Given this list of marker genes HSP90AA5P, KIFC2, HSP90AB1, ASCC3, ATP2B2, KIF22, KIF1A, ACTB, BCS1L, DNAH3, ABCA1, ATP5F1B, TAP1, DDX50, HSP90AA2P, DDX60, KATNA1, ATP9B, KIF2A (kinesin family member 2A), CHD3, HSP90B2P, KIF20A, SMC1B, CCT5, RAD51 (RAD51 recombinase), KIF5C (kinesin family member 5C), MTREX (NCBI Gene Id 23517), RIGI, FIGNL1, ATP10A, VPS4A, NLRP1, PMS2P1, KIFC1, ATP10D, CLPX, HSPA1B, BRIP1, TCP1 (NCBI Gene Id 6950), ABCF3, SNRNP200, ATP11C, ABCC3, DDX24, DDX59, PMS2, AFG1L, PSMC6, SHOC1, ATP6V1G2, ATP2A3, KIF6, MCM3 (NCBI Gene Id 4172), ATAD1, SWSAP1, INO80, ATP8B2 (NCBI Gene Id 57198), DNAH7, NLRP3, MSH2, DMC1, DDX47, RUVBL1, RFC5, KIF19 (NCBI Gene Id 203397), ACIN1, CCT6B, POLQ, ABCC8, BLM, DDX20, RUVBL2, FBH1, HELQ, TWNK, HSPA7 (heat shock protein family A (Hsp70) member 7 (pseudogene)), ALPL, RAD50, CDC6, ATP6V1G3, EIF4A2, KIF5B, GPN1, MCM6, VWA8, KIF1B, CHD9, SRP54 (signal recognition particle 54), DDX1, DHX40, DHX38, TRAP1, C10orf88, FIGN, DHX9, CFTR, ABCB7, KIF3C, CLPB, DDX23, SMC4, ABCF1, CCT6A, PIF1, DNAH9, TOR4A, ORC4, CHTF18, ERCC3, DNAH6, ABCC1, HSPA8, SMC3, ATP2C1, EIF4A3, KIF20B, ABCG2, ABCA4, GET3, DDX55, CHD1, ERCC2, ABCD1, XRCC6, MDN1 (NCBI Gene Id 23195), YTHDC2, NAV1, HSP90AB4P, KIF12, NAIP, KIF16B, SUPV3L1, VCP, ATP13A5, TDRD9, ATAD5, RFC2, ABCC5, KIF5A, SPG7, LONP1, ATAD3B, CHD2, ATP9A, CARNS1, RAD54L2, ABCC11, ATP10B, FANCM, ATP13A3, MCM8, KIF28P, HELB, SMC1A, MYO19, ABCB10, ABCG5, ATP13A2, ATP13A4 (ATPase 13A4), ERCC6L, KIF27, HSPA2, MYO3A, NAV3, NAV2, DHX34, KIF13B, KIF26A, ABCB6, ABCA6, HFM1 (NCBI Gene Id 374992), ATF7IP, DDX18, DDX60L (DExD/H-box 60 like), SMC5, NSF, ATAD3C, SMPDL3A, CCT8, HSP90AB2P, DDX42, UPF1, DHX8, KIF18B, KIF25 (NCBI Gene Id 3834), SRPRA, DDX19B, SMCHD1, PMS2P5, ABCG4, DDX25, CCT2, DHX16, NLRP10, KATNAL1, IQCA1, SLFN11, TDRD12, OLA1, ABCA9, MOV10, SMARCA5, KIF17, ABCA8, DHX35, ATP2B4, ABCA12, HSPD1, ATP6V1G1, PSMC4, ABCB11, DDX6, PMS2P6 (NCBI Gene Id 729453), DHX58, DHX15, ABCC9, SMC2 (structural maintenance of chromosomes 2), SMARCAD1, MCM7, ENTPD1, CCT7, RNF213, HSPA1L, BTAF1, MCM5, MYH8, DDX51, RSF1, NTPCR, ABCD2, ATP1A4 (NCBI Gene Id 480), ABCC6, XRCC5, MYO18A, TOR1B, CHD8, KIF3B, AQR, ABCB5, RAD54L, RFC1, TOR3A, ABCG1, DHX30, ABCA13, AFG3L2, PFN2, DDX28, ATP4A, HSP90AA4P, DDX5, ATP5F1A, HSP90B1, KIF21A, IQCA1L, DDX3X, CHD6, MCM2, MYH4, CCT4, RAD51D, SKIC2, WRNIP1, ATP5F1C, VPS4B, HSP90AB3P, KIF7, SMC6, KIF18A, DHX33, DDX41, PEX1, KIF15, PSMC2, DNAH10, ERCC6, KIF9 (kinesin family member 9), ATP1A3 (NCBI Gene Id 95633), MYO5A, IDE, RECQL, ABCE1, KIF13A, RFC4, ABCA5 (ATP binding cassette subfamily A member 5), TOR1A, ABCC4, DDX3Y, COQ8B, CHD4, ABCD4, MCM4, ATAD2, RTEL1, ABCB8, NUBP1, KIF3A, CHD1L, ATP12A, RHOBTB3, ABCC12, DDX27, MLH1, RECQL4, ATP8A1, KATNAL2, HSPA1A, ATP2C2, PEX6, DDX19A, HSPA14 (heat shock protein family A (Hsp70) member 14), KIF2B, DQX1, ABCA3, DDX39A, PMS1, ATP13A1, FIGNL2, ATP6V1A, ORC1, ABCC2, DDX11, ABCB4, DHX32, DDX17, ATAD3A, CCT3, CHD7, ATP2B1, ATP11A (NCBI Gene Id 84170), ABCA7, DDX10, DYNC1H1, ATP8B3, SPAST, DNAH2, ATP8A2, ATP2A2, ATP1A2, DDX49, MCM9, DNAH11 (dynein axonemal heavy chain 11), PSMC5, LONP2, SRCAP (NCBI Gene Id 10847), TRIP13, AK9, DDX31, HSPA6, MORC3, ABCA10, DDX46, MORC4, ATP8B4 (ATPase phospholipid transporting 8B4 (putative)), DDX54, MORC2, NVL, KIF23, DDX4, AFG2B, ABCB9, ATP11B, DHX36, ATP7A, ABCG8, DHX37, ABCA2, KIF14, CLU, HSPA13, IGHMBP2, DDX56, EIF4A1, G3BP1, DDX53, ATP8B1, DHX57, PSMC1, IFIH1, ATP2B3, YME1L1, AFG2A, KIF2C, KIF1C, ATP2A1, KIF21B, HSPA9, DHX29, DDX52, TOR2A, HELZ2, MLH3, ATRX, PMS2P3, ABCF2, ABCD3, DNA2, MYO9B, CHD5, AK6, ATP6V1H, ATAD2B, PSMC3, RAD51B, ABCC10, DNAH12, DDX43, MYH3, MOV10L1, WRN, RECQL5, ATP5PO, DDX39B, DNAH8, HSPA5, ATP7B, DDX21, DNAH5, TAP2, RFC3, DYNC2H1, HSP90AA1, MYO1E, ATP1A1, ABCB1, here is a description of the gene set: Catalysis of the reaction: ATP + H2O = ADP + H+ phosphate. ATP hydrolysis is used in some reactions as an energy source, for example to catalyze a reaction or drive transport against a concentration gradient. species: Homo sapiens Human Gene Set: GOMF_ATP_HYDROLYSIS_ACTIVITY